Given this list of marker genes BLM, RFC5, RAD17, RPA1, ATRIP, RAD9A, RAD50, RFC3, PALB2, RMI2, RAD9B, RBBP8, RAD51AP1, NBN, RHNO1, RAD51, TOPBP1 (NCBI Gene Id 11073), XRCC2, SEM1, RPA2, BRCA1, BRCA2, ATM, RAD1, BARD1, EXO1, BRIP1, RPA3, RAD51D, HUS1, CHEK1, RFC4, ATR, RFC2, XRCC3, RAD51C, MRE11 (MRE11 homolog, double strand break repair nuclease), WRN (WRN RecQ like helicase), KAT5, TOP3A, RMI1, DNA2, RAD51B, here is a description of the gene set: Homologous DNA Pairing and Strand Exchange species: Homo sapiens Human Gene Set: REACTOME_HOMOLOGOUS_DNA_PAIRING_AND_STRAND_EXCHANGE